The following is a description of a gene set: A multicellular organismal process involved in the periodic casting off and regeneration of an outer covering of cuticle, feathers, hair, horns, skin. Human Gene Set: GOBP_MOLTING_CYCLE_PROCESS species: Homo sapiens, and this is the list of marker genes: COL6A1, NSUN2, APCDD1, MSX2, BCL2, TMEM79, GNAS, TP63, NUMA1, TNFRSF19, RELA, EDAR, SPINK5 (serine peptidase inhibitor Kazal type 5), SHH, RBPJ, PIAS4, CD109 (NCBI Gene Id 135228), LRP4 (NCBI Gene Id 4038), EDA, KRT25, SOX18, KRT17, KRT28, EGFR, NOTCH1, KRT84, LAMA5, TGM3, NOM1, MYSM1, SOS1, DSC1, NAGLU, WNT10B, FOXE1, SOX21, TRPC4AP, HDAC1, FERMT1, ERCC2, CDH3, LGR5, SAV1, LRIG1, TSPEAR, HOXC13, GORAB, FOXN1, LHX2, DKK1, TNF, DKK4, FOXQ1, SMAD4, PUM2, KRT27, WNT10A, FZD3, TFAP2C, PDGFA, FOXI3, LDB2, EXT1, WNT5A, PLA2G10, DNASE1L2, NGFR, FGFR2, FST, LGR4, SNAI1, VANGL2, DLX3, HPSE, FGF7, FGF10, INHBA, FUZ, INTU, FARP2, ALX4, HDAC2, LDB1, DSG4, IGFBP5, NSDHL, ZMPSTE24, KRT71, SOX9, ACVR1B, TRADD, GLI2, TGFB2, SMO, ZDHHC21, CTNNB1, GAL, SOSTDC1, NF1, FZD6, PKP3, ATP7A